The following is a description of a gene set: studied in species Homo sapiens Genes predicted to be targets of miRBase v22 microRNA hsa-miR-192-5p in miRDB v6.0 with MirTarget v4 prediction scores > 80 (high confidence targets). from publication Chen Y, Wang X (PMID 31504780) Human Gene Set: MIR192_5P, and this is the list of marker genes: PABPC4 (poly(A) binding protein cytoplasmic 4), SCN3A, IFI44L, NIPAL1, LPAR4, PCDH7 (NCBI Gene Id 90855), WDR44 (NCBI Gene Id 54521), ZEB2, OSBPL10, CAMSAP2, STX7, PREPL, TMPO, RAB2A, CRYBG3, ARFGEF1, UTP25, CXCL2, MTMR4, ANAPC10, EREG, DYRK3, FRMD4B, PRKD3 (protein kinase D3), SRSF6, WNK1, BHLHE22, TMLHE, NKAIN2, MCPH1 (NCBI Gene Id 79648), RPAP2, PDP1, ATF1, DNAH5, NSF, PCDH9